Given this list of marker genes GATA3, IL33, IL17RA, CRLF2, IL17RB (NCBI Gene Id 55540), IL1RL1, PRKCZ, RARA, IL9, IL1RAP (NCBI Gene Id 3556), TSLP, PDE4D, here is a description of the gene set: Human Gene Set: GOBP_POSITIVE_REGULATION_OF_INTERLEUKIN_5_PRODUCTION Any process that activates or increases the frequency, rate, or extent of interleukin-5 production. species: Homo sapiens